Given this list of marker genes Cuedc2, Tgfb2, Tgfb3, Atg9a, Twist1, Prg2, Epx, Tgfb1, Axl (AXL receptor tyrosine kinase), Acp5, Nlrx1, Irak3, Nod2, Twist2, here is a description of the gene set: species: Mus musculus Any process that decreases the rate, frequency or extent of macrophage cytokine production. Macrophage cytokine production is the appearance of a chemokine due to biosynthesis or secretion following a cellular stimulus, resulting in an increase in its intracellular or extracellular levels. Mouse Gene Set: GOBP_NEGATIVE_REGULATION_OF_MACROPHAGE_CYTOKINE_PRODUCTION